Given this list of marker genes MTND3P20, TAB2, RAET1E, RMND1, UST, MTRF1L, TCP1, MTCO2P31, LINC02529, ZC3H12D, SLC22A2, AIRN, SCAF8, TAGAP-AS1, FNDC1-IT1, SYNJ2-IT1, OPRM1, TULP4, TMEM242, FNDC1-AS1, ENSG00000278899, SNORA29, RNU6-786P, PLEKHG1, RNU6-293P, MTHFD1L, PDCL3P5, FNDC1, LINC02840, ENSG00000271551, NANOGP11, MTCO3P31, RNU4ATAC18P, AKAP12, RNU6-302P, C11orf98P2, H3P28, RNA5SP225, SYNE1, SOD2, ENSG00000227360, HSPE1P26, IYD, MIR3692, ENSG00000301114, ENSG00000202343, PPIL4, RN7SL234P, ESR1, ZDHHC14, RPS18P9, RPSAP40, ENSG00000300966, GTF2H5, AMZ2P2, MTND4LP20, SYNE1-AS1, SNX9-AS1, RN7SKP268, SYTL3, TFB1M, ACAT2, SLC22A3, FABP12P1, MAS1, RNU6-300P, SYNJ2, RNU4-7P, MYCT1, HSPA8P15, MIR7161, RNA5SP224, ENSG00000238594, MTND4P13, RNY4P20, SUMO4, UST-AS2 (UST antisense RNA 2), CCT7P1, RPL21P69, TMEM181, ENSG00000287260, BTF3P10, RPL31P29, RNA5SP223, SNORA20, CACYBPP3, ZBTB2, EZR, ENSG00000305281, CNKSR3, RAET1G, MTRES1P1, MIR1273C, TAGAP, RAET1K, ENSG00000296645, ENSG00000224478, MRPL18, SRP72P2, LINC02901, SLC22A1, ARL4AP5, ULBP2, RN7SL173P, ENSG00000273132, ARID1B, RGS17, RAET1M, RPS4XP8, ENSG00000237312, RPL32P16, TUBB4BP7, RSPH3, TATDN2P2, RNU6-824P, RAET1E-AS1, LRP11, HNRNPH1P1, RNU6-896P, SOD2-OT1 (NCBI Gene Id 100129518), GINM1, SERAC1, CLDN20, HMGB3P19, OSTCP1, IGF2R, LPAL2, PCMT1, SNRPEP6, SSR1P1, UST-AS1, RPL17P24, RNU7-3P, ENSG00000285492, NUP43, TMEM242-DT, ULBP3, VIP, RAET1L, WTAP, RNU6-813P, MIR4466, LDHAL6FP, MIR1202, TIAM2, BTBD10P2, KATNA1, ENSG00000293239, MIR3918, SNORD28B, NOX3, IPCEF1, FBXO5, ENSG00000226193, RNU6-1247P, PPP1R14C, DYNLT1, MTATP6P31, LATS1, ULBP1, PNLDC1, ENSG00000223598, RNU7-152P (NCBI Gene Id 106479081), TAB2-AS1, SNX9, CCDC170, CHP1P2, PHB1P1, ARMT1, HSPD1P16, EZR-AS1, here is a description of the gene set: Human Gene Set: chr6q25 studied in species Homo sapiens